Given this list of marker genes Gng3, Gng10, Gng5, Gnb3 (NCBI Gene Id 14695), Gng7, Prkar1b, Rictor, Calm1, Gnb5, Gng11, Prkar2b, Adm, Pdpk1, Gngt1, Gng8, Gnb2, Prkacb, Gng4, Capns2, P2ry2, Prkaca, Gngt2, here is a description of the gene set: part of: Response of endothelial cells to shear stress electronically inferred by orthology from the curated human pathway Reactome Pathway: High laminar flow shear stress activates signaling by PIEZO1 and PECAM1:CDH5:KDR in endothelial cells This event has been computationally inferred from an event that has been demonstrated in another species.<p>The inference is based on the homology mapping from PANTHER. Briefly, reactions for which all involved PhysicalEntities (in input, output and catalyst) have a mapped orthologue/paralogue (for complexes at least 75% of components must have a mapping) are inferred to the other species. species: Mus musculus